The following is a description of a gene set: studied in species Homo sapiens Human Gene Set: GSE5455_EX_VIVO_VS_POST_24H_INCUBATION_MONOCYTES_FROM_TUMOR_BEARING_MOUSE_DN from publication Gallina G, Dolcetti L, Serafini P, De Santo C, Marigo I, Colombo MP, Basso G, Brombacher F, Borrello I, Zanovello P, Bicciato S, Bronte V (PMID 17016559) Active suppression of tumor-specific T lymphocytes can limit the immune-surveillance and immunotherapy efficacy. While tumor-recruited CD11b+ myeloid cells are known mediators of tumor-associated immune dysfunction, the true nature of these suppressive cells and the fine biochemical pathways governing their immunosuppressive activity remain elusive. Here we describe a population of circulating CD11b+/IL-4Rα+, inflammatory-type monocytes that is elicited by growing tumors and activated by IFN-γ released from T lymphocytes. CD11b+/IL-4Rα+ cells produce IL-13 and IFN-γ and integrate the downstream signals of these cytokines to trigger the molecular pathways suppressing antigen-activated CD8+ T lymphocytes. Analogous immunosuppressive circuits are active in CD11b+ cells present within the tumor microenvironment. These suppressor cells challenge the current idea that tumor-conditioned immunosuppressive monocytes/macrophages are alternatively activated. Moreover, our data show how the inflammatory response elicited by tumors has detrimental effects on the adaptive immune system and suggest novel approaches for the treatment of tumorinduced immune dysfunctions. Genes down-regulated in ITGAM+ cells from spleens of tumor bearing mice: processed immediately versus those incubated for 24h in complete medium., and this is the list of marker genes: SLC45A4, ANKRD7, C5orf34, DGKA, PTPRE, ITSN2, TP53TG5, CD96, RNF32, SGK1, C19orf38 (NCBI Gene Id 255809), SLCO2A1, ADIPOQ, SUPT4H1, NCK1, SLFN5, NOTCH4, XAF1, WFIKKN2, ARMC3, SKAP2 (src kinase associated phosphoprotein 2), RPS6KA1, SLAMF9, IFIT1B, SEPTIN4, HUWE1, TMEM14A, RASA3, KLHDC1, RGS14, RPL19, SCML4, CCS, PGS1, USP18, CLCF1, EVI2B, MBTD1, EMB, KIF1B, RAMP3, EPC1, ACP5, NR2C2AP, RIN2, IRAK3, RTP4, IFIT1, NCKAP5L, EEIG1, FAM3C, ENTREP3, SAMD9L, PLTP, ID3, RIGI, RSRP1, ACAP1, C1orf185 (NCBI Gene Id 284546), MAP3K1 (NCBI Gene Id 4214), ASPHD2, WIPI1, INPP5B, ZNF274 (zinc finger protein 274), MYOC, TPR, CABCOCO1, IRF9, TBC1D30, RFLNB, GATA1, ITGA4, ZSCAN26, KLF2, MGST2, F12, RCOR3, RPL30, CTSA, HOXB6, SDCBP2, PGLYRP2, GAB1, IFIT3 (NCBI Gene Id 8376), ADGRE5, STK10, SGMS1, FCGR2A, CD300LB, HVCN1, LFNG, TLK1, NUPR2, PRKX, C17orf58, TECPR1, SEMA4F (ssemaphorin 4F), ACSS1, IZUMO1R, SPACA9, GRK4, NDOR1, PPP1R17, C2orf68 (chromosome 2 open reading frame 68), UBASH3B, MUC1, CAPS2, MGRN1, LEAP2, ARMC7, RREB1, UTRN, ALOX12B, DCAF7, BCL3, MOB3B, CLINT1, PPIP5K2, PRKACB, ZNF646, GPNMB (glycoprotein nmb), FOXC2, TTLL7, NADK2, PMM2, ITGA6, ARHGEF1, CRLF3, TNK2, SHARPIN, RGS4, TTC17, GPR137B, L1TD1, STK4, TMEM71, PITPNC1, SHD, NIBAN1, ZNF3 (zinc finger protein 3), RASGRP1, TNFSF10, MSL2, MAST1, LIAT1, NFE2L3, GALNT3, MS4A15, F2RL1, OSM, TRIM36 (tripartite motif containing 36), CALCRL, KBTBD11, IFI35, MEX3B, S1PR4, DEDD2, HS3ST3B1 (heparan sulfate-glucosamine 3-sulfotransferase 3B1), ETV3, ZNF652, RYR1, RNF213, EYA2, SLAMF6, USP3, ARHGAP4, ARID5A, RNF19A, ASB17, OTULINL, POSTN (periostin), FAM98C, ABCB1, ITGA7, LRTM1, RAPGEF4, ICAM2, CLCN4, FHIP2A, GABRR2, IL7R, DCTN6, PLEKHN1, CCM2 (CCM2 scaffold protein), MYL12B, SLC4A7, IL4R, SLC25A24, SLC35C1, PDCD2, DOCK10, SLC25A23, SFN, OAS2, KRT39, AKT3, GMFG, SULF2, S1PR1, USP38